The following is a description of a gene set: species: Homo sapiens The chemical reactions and pathways involving heparan sulfate proteoglycans, which consist of a core protein linked to a heparan sulfate glycosaminoglycan. The heparan sulfate chain is composed of the repeating disaccharide unit beta-(1,4)-N-acetyl-D-glucosamine-alpha-(1,4)-hexuronic acid, the former being either sulfated or deacetylated on its amino group as well as sulfated on one of its hydroxyl groups, and the latter being a mixture of sulfated and nonsulfated D-glucuronic and L-iduronic acids. Human Gene Set: GOBP_HEPARAN_SULFATE_PROTEOGLYCAN_METABOLIC_PROCESS, and this is the list of marker genes: HS6ST1, EXTL1, NDST3, HS2ST1, NDST4, CTNNB1, HS3ST6, EXTL3, CSGALNACT1, IDS, HGSNAT, HS3ST3A1, HS6ST3, IDUA, GPC1 (glypican 1), NDST2, SLC35D2, GUSB (glucuronidase beta), HS3ST2, TM9SF2, VANGL2, HPSE, GNS, HS3ST3B1, HS3ST4, EXT1, UGDH, SULF2, XYLT1, HS3ST5, HS3ST1, HS6ST2, PXYLP1 (NCBI Gene Id 92370), SULF1, NDST1, GLB1, XYLT2, B3GALT6, DSE, SGSH (NCBI Gene Id 6448), EXT2, NAGLU, GLCE, TCF7L2, B3GAT3, EXTL2